The following is a description of a gene set: Genes up-regulated in HMC-1 (mast leukemia) cells: untreated versus stimulated with T cell membranes. We demonstrate that the G protein Gi3 is the cellular target of the adenosine A3 receptor (A3R). By using a cell permeable peptide comprising the C-terminal end of Gαi3 fused to an importation sequence (ALL1) as a selective inhibitor of Gi3 signaling, we show that by coupling to Gi3, the A3R stimulates multiple signaling pathways in human mast cells, leading to upregulation of cytokines, chemokines and growth factors.Following contact with activated T cell membranes, endogenous adenosine binds to and activates the A3R, resulting in Gi3-mediated signaling. Specifically, the majority of ERK1/2 signaling initiated by contact with activated T cell membranes, is mediated by Gi3, giving rise to ALL1-inhibitable cellular responses. These results unveil the physiological GPCR that couples to Gi3 and establish the important role played by this G-protein in inflammatory conditions that involve adenosine-activated mast cells. We used microarrays to detail the effect of ALL1 on gene expression of HMC-1 cells activated directly by the A3 receptor, or by contact with activated T cell membranes. Human Gene Set: GSE19888_CTRL_VS_T_CELL_MEMBRANES_ACT_MAST_CELL_UP studied in species Homo sapiens from publication Baram D, Dekel O, Mekori YA, Sagi-Eisenberg R (PMID 20190146), and this is the list of marker genes: TACC3, UBQLN4, HSF2, PPP2R2A, MSN, GARS1, DNAJB11, RBIS, FNBP4, SRRM1, PDPK1, REM2, RHOA, CCNL1, YTHDC2, CHAMP1, NDUFA3, DCLRE1C, WDR89, ZNF565, SNX1, ZNF281, ZNF490, GCA, SUDS3, COPS7B, UNC50, DDX55, HTATSF1, KLHL7, FAU, AMPD2, RBMX, KIF24, WIPI2, KIAA1958, DCTD, BAG1, VPS37A, MIGA1, SAE1, IGF1R, UBL4A, DNTTIP1, PSMD14, FBXL5, ZC3HAV1, ABI1, UFM1, RCN2, RANBP9, CRIP2, PSMC6, RAP1B, FPGT, ZMYM4, CSGALNACT2, NOPCHAP1, BCL2L13, HNRNPC, TOP1MT, SLC29A1, LARP7, ALS2, RAD17, TTC32, RPS21, AK2, CDR2, PPFIBP1, PER1, ZFP36L1, B2M, GEMIN5, MED17, COX5A, TMEM192, CA2, BRD2, ATPAF2, YBX3, SLC35E2B, HIRIP3, TTF1, RELL1, ZNF277, TRIOBP, LSM2, ROCK2, FBXO3, TRIM27, MYPN, GADD45A, ADORA2A, ALKBH5, CISD1, NAE1, RABL3, PACRG, DEDD, EIF2B1, UBE2J2, STRN3, KCNB1 (potassium voltage-gated channel subfamily B member 1), MRS2, POMP, MAGI3, ADSL, APIP, SLC25A13, UBA5, SPAG4, IRAK1BP1, GLS, CIRBP, ECHDC1, VEGFA, NUP37, RBM15, VPS33B, COA5, FKBP4, BDKRB2, USP54, PDHA1 (NCBI Gene Id 5160), C17orf100, DDI2, ANXA7, SLC25A39, PI4K2B, HARS1, UXS1, DDX19B, MRPL10, ARL5A, METTL6, BAG4, ARL4A, NBEA, ORC4 (NCBI Gene Id 5000), MIEF2, STAU1, PSPC1, ZNF48, CLN3, TMBIM1 (transmembrane BAX inhibitor motif containing 1), IL6, AURKA, MSS51, NEB, TRIM23, DGAT1, SLC25A3, NAA35, SHMT1 (serine hydroxymethyltransferase 1), NOB1, NUP85, TEX15, PITHD1, CGAS, GID4, MRPL45, DNM1L, USP1, MAP1LC3A, SPSB2, CDKAL1, NDST3, CUL1, DDX46, ZDHHC5, CHMP1A, LAMP1, ST8SIA4, RPS6, SLC25A26, MRPL41, DCTN3, RAB5A, HAUS3, LCE1A, PLCL2, CPNE1, METTL3, COX18, PHC2, ADGRE5, GCFC2, EPB41L4A, RIMOC1, SP1, AFMID, MTOR, LAS1L, PLAGL1, ZNF638, C1orf52, ACO2, INO80D, EXTL2